Given this list of marker genes PRSS48, CHRNA7, TRPM6, ALG1L6P, GREB1L, FGF12, SLC5A4, LINC03002, ETS2-AS1, ENSG00000259072, GCOM1, MIR34AHG, LINC01545, MYRIP (NCBI Gene Id 25924), CHRM3, ZNF503-AS1, AFAP1L1 (actin filament associated protein 1 like 1), UNC80 (NCBI Gene Id 84540), LINC02356, PROX1-AS1, RAPGEF5, SNCAIP, ADAMTSL1, GABBR2, PTPRB, NOSTRIN, SOX7-AS1, SIPA1L1, ENSG00000248636, CALCR, OR5G5P, CIMAP1D, LINC02160, ERG, CYYR1, BTNL9, KIAA1671, SNTG1, PTCHD4, HOXD3, STAB2, FAP, TMEM233, BBOX1-AS1, KLHL4, CALCRL, ADGRL4, GALNT18, DGKE, TACR1, LRIG3, EEF1A1P31, B3GNTL1P1, MAGI1-IT1, RFX8, RGS7BP, HECW2, LINC01594, MAGI1, MECOM, THSD7A, here is a description of the gene set: from publication Cao J, O'Day DR, Pliner HA, Kingsley PD, Deng M, Daza RM, Zager MA, Aldinger KA, Blecher-Gonen R, Zhang F, Spielmann M, Palis J, Doherty D, Steemers FJ, Glass IA, Trapnell C, Shendure J (PMID 33184181) Marker genes curated from the annotated cluster as represented in the Descartes Human Gene Expression During Development database. studied in species Homo sapiens The gene expression program underlying the specification of human cell types is of fundamental interest. The study authors generated human cell atlases of gene expression and chromatin accessibility in fetal tissues. For gene expression, the study authors applied three-level combinatorial indexing to >110 samples representing 15 organs, ultimately profiling ~4 million single cells. The study authors leveraged the literature and other atlases to identify and annotate hundreds of cell types and subtypes, both within and across tissues. Our analyses focused on organ-specific specializations of broadly distributed cell types (such as blood, endothelial, and epithelial), sites of fetal erythropoiesis (which notably included the adrenal gland), and integration with mouse developmental atlases (such as conserved specification of blood cells). These data represent a rich resource for the exploration of in vivo human gene expression in diverse tissues and cell types. Human Gene Set: DESCARTES_FETAL_SPLEEN_VASCULAR_ENDOTHELIAL_CELLS